Given this list of marker genes Gm20610, Lims1, Mir7215, Fam241b, Slc29a3, Gm26947, Pbld2, Gm28447, Smpdl3a, P4ha1 (NCBI Gene Id 18451), Gm31931, Macroh2a2, Oit3, Slc25a16, Gm18514, Lrrc20, Tet1, Pkib, Mir6408, Rnf7l, Gm24285, Septin10, Gm16143, 4930507D05Rik, Stox1, Tspan15, Rpl48-ps1 (ribosomal protein L48, pseudogene 1), 4930467K11Rik, Snord98 (NCBI Gene Id 100217463), Vsir, Srgn, Tysnd1, Ppa1 (pyrophosphatase (inorganic) 1), Gm16128, Ddx50, Gm36595, Chst3, Mir466j, Gm25526, Mir6906, Gm18042, Sar1a, D830039M14Rik, Gm40652, Gm20611, Sirt1 (sirtuin 1), Adamts14, Gm23058, Gm17455, Duxf1, Duxf2, Rufy2, Gja1, Pald1, Npffr1, Kifbp, Gm47593, Tbata, Hnrnph3, Unc5b, 1700120B22Rik, Hk1os, Tbc1d32, Dna2, Serinc1, Lrrtm3, Ccar1, Eif4ebp2, Rpl27a-ps1, Hsf2, Prf1, Psap, Anapc16, Mcu, Duxf3, 1700022H01Rik, Herc4, Gm47261, Pbld1, Duxf4, Supv3l1, Hk1, Neurog3 (neurogenin 3), Aifm2, Gm5777, Gm17829, Tacr2, Sowahc, Ctnna3, Gm10322, Gm5750, Dnajb12, Micu1, Mypn, Col13a1, Gm7001, Mir5108, Gm26479, BB019430, Fabp7, Cdh23, Gm19256 (predicted gene, 19256), Atoh7, Ranbp2, Gm9129, Pla2g12b, Ccdc138, Gm7399, Vps26a, Gcc2, Gm6494, Hkdc1, Gm25862, Nodal, Ascc1, Dnajc12 (DnaJ heat shock protein family (Hsp40) member C12), Pldi, Gm17059, Gm10118, Ddx21, Gm23223, Ddit4, Gm7413, Edar, Gm5424, Rps8-ps1, 4930452L12Rik, Gm9118, Gm9795, Sgpl1, Gm19972, Gm10273, 4933428P19Rik, Gm19337, Gm7530, Pcbd1, Gm36827, Spock2, Mir7662, Sh3rf3, here is a description of the gene set: Mouse Gene Set: chr10B4 species: Mus musculus